The following is a description of a gene set: Mouse Gene Set: REACTOME_METABOLISM_OF_PROTEINS Metabolism of proteins studied in species Mus musculus, and this is the list of marker genes: Mrps21, Rab17, Mgat1, Rps26, Copz2, Jmjd7, Large2, Cul4a, Gfpt1, Rpl36al, Ctsc, Mrpl41, Uqcrc2, Manea, Dcun1d1, Nsf, Abraxas2, Ide, Apol10a, Rab7, Ttll10, Mgat4a, Rps14, Glud1, H4c16 (NCBI Gene Id 674678), Eif2s2, Fut11, Napb, Ddb2, Asb4, Cdca8, St6galnac1, Arf3, Fbxl13, Dolk, Spcs3, Thra, Eif3b, Twnk, Lipt2, Spon1, Actr1a (NCBI Gene Id 54130), Srp14, Wfs1, Mgat4c, Ndufv1, U2af2, Enam, Rpl35a, Eif3j2, Ggcx, Adora2a, Mrps30, Exoc2, Trappc3, Cul3, Ube2s (ubiquitin-conjugating enzyme E2S), Adamts13, Gps1, Eci1, Taf10, Socs6, Neu2, Mbd1, Adamts15, Fbxl7, Thsd1, Dap3, Tectb, Tnip3, Msrb2, Sec11a, Mrpl11, Rpl18, Nrip1, H2bc21, Zdhhc2, Calm1, Apol7b, Ring1, Usp33, St6gal1, Keap1, Uso1, Rpl5, H4c6, Gadd45gip1, H2bc1, Sptan1, Gmppb, Adgrf5, Clspn, Dync1i1, Cnih3, Eef1akmt1, Atp5mg, Ldhd, Usp17ld, Adamts19, Tnip1, Uba1, Galntl6, Psmc2, Mysm1, Cish, Galnt18, Muc6, Mrps15, Pias1, Mrps34, St8sia2, Chst8, Gnb1, Gnb5, Usp42, Rps9, Rab8a, Cdc73, Inhba (NCBI Gene Id 16323), Commd3, Rab25, Mrpl13 (mitochondrial ribosomal protein L13), Rps4x, Vdr, Fbxl16, Nop58, Nedd8, Nod2, St6gal2, Nup155, Dpp4, Aplp2, Dctn2, Mettl22, Spaca4, Trappc9, Notum, Pomc, Rpl35, Cct7, Tmed3, Rpsa, Serpind1, Rplp2, Ctsg, Gpihbp1, Cope, Psme3, Slc34a1, Fbxw17, Bdh1, Slc30a8, Chst10, Ly6d, Smad4, Exoc8, Fkbp8, B3gnt7, Gfpt2, Chchd1, F7, Galntl5, Txn1, H2bc9, Rpl11 (NCBI Gene Id 67025), Traf3, Thsd7a, Ino80c, Eif2s3x (NCBI Gene Id 26905), Fech, Srd5a3, Mrpl42, Nagk, Pdhb, Ube2t, Msrb1, Ube2f, Bard1 (BRCA1 associated RING domain 1), Qsox1, Rora, Ep300, Xrcc4, Sec24d, Oxsm, Arsk, Dhps, Alg12, Hnrnpc, Wdr48, Dync1i2, Pgap1, Mrpl3, Ripk1, Psmb11, Kctd6, Dcaf7, Wdtc1, Dohh, Gan, Prkaca, Tada3, Asb17, Pigz, Mdm2, Etf1, Smad2, Arrb2, Ly6g6c, Usp15, Ube2c, Il6, Ogt, St6galnac2, Pigk, Eif4ebp1, Dctn1, Mrps18c, Usp29, Tuba3b, Eif5b, Gnb4, Srp9, Fcgr4, Cog6, Rpl6, Psg22, Pomk, Esr1, Mme, Asb11, Mrpl55, Dcaf4, Arsj, Sp3, Actr8 (ARP8 actin-related protein 8), Ace (angiotensin I converting enzyme), Apol10b, Slc35c1, Asb6, Polb, Igfbp5, Trappc10, Commd6, Rpl10l, Mrpl52, Socs3, Rab7b, Eif3a, Adamts7, Ttll12, Golgb1, Apc, Rab9b, Dctn3, Alppl2, Hif1a, Ufd1, Skp2, Vnn1, Gngt2 (guanine nucleotide binding protein (G protein), gamma transducing activity polypeptide 2), Ubxn7, Usp30, Fem1b, Lypd2, Klhl5, Commd10, Pex2, Nup188, Ttf1, Sptb, Dctn6, Cnih2, Ube2a, Fbxl19, Cdc20, Copg1, Pex12, Ddx17, Suz12, Ppp6c, Fam20c, Tnks, Tmed2, Hspa9, Chst4 (NCBI Gene Id 26887), F10, Muc15, Galnt4, Klhl20, Ccdc59, Msln, Cog8, Shisa5, Hipk2, Tuba1c, Nup93, Gne (glucosamine (UDP-N-acetyl)-2-epimerase/N-acetylmannosamine kinase, NCBI Gene Id 69688), Psmb5, Ly6g6d, Pex13, Csf1, Asgr2, Spg7, Arg2, Srp54a, Psmc4, Pigw, Lman2, Trappc6b, Tubb4b, Csnk1d, Fgg, Nadk2, Shprh (NCBI Gene Id 70331), Slc34a2, Tada2b, Iars2, Galnt11, Uba6, Ogfod1, Cs (citrate synthase), Izumo1r, Siah2, Proz, Hadh (hydroxyacyl-Coenzyme A dehydrogenase), Fbxw5, Rps19, Galnt9, Usp2, Idh2, Rps10, Nans, Mrps31, Mrps23, Cog3, Btbd1, Gpc3, Usp10, Slc25a5, Pigl, Rnf146, Lrrc41, Dlst, Psma4, Paf1, Pml, Lrr1, Klhl22, Uhrf2, Kbtbd7, B4galt4, Engase, Senp1, Rigi, Rab15, Pias2, H2bc24, Cd59b, Stc2, Pofut2, Hspd1, Atp5po, Nr1h3, Galnt10, Rps27l, St6galnac6, Klhl42, Eif4e, Uchl5, Pigm, Sumf1, Sec22b, Exoc4, Seh1l, Nup88, Spp2, H4c9, Muc4, Yy1, Dmp1, Pros1, Rnf181 (NCBI Gene Id 78347), Usp12, Tubb2a, Nsmce4a, Rps3a1, Rpl26, Eif3e, Igf2 (NCBI Gene Id 16002), Serpinc1, Psme2b, Mxra8 (NCBI Gene Id 74761), Rab43, Psmb6, Cntn3, Pdha1, Ube2d1, Man1a2, Ube2e3, Ranbp2, B4gat1, Blm, Apol8, Sae1, Mrps18a, Usp47, Rps11 (ribosomal protein S11), Stambp, Eif3c, H2bc6, Adamts5, Tshb, Xpnpep2, Nr1i2, Rab20, Gna11, Asb10, Fbxo30, Mrps36, Mrpl44, Eid3, Srp19, Usp9x, Dmbt1, Dph1, Amtn, Mrps22, Asb9, Mrps10, Pccb (NCBI Gene Id 97574), Reck, Arcn1, Mdc1, Tbc1d20, Atp5f1c, Sec24a, Ace2, Arfgap2, Eif5, Usp17lc, Usp13, Ube2k, Tpr, Rps8, Mrpl20 (NCBI Gene Id 73950, mitochondrial ribosomal protein L20), Axin2, Sumf2, Cpm (carboxypeptidase M), Fbxw9, H2ac21 (NCBI Gene Id 632183), Apol7c, Eif2b2, Rbx1, Apol7a, St8sia4, Ube2q2, Prnd, H4c8, Foxk1, Pla2g7, Rnf144a, Apol11a, Trappc1, Ddx5, Dph6, Ccnf, Ino80d, Mrps27, Apoa5, Igf1, Grp, Kdm1b, Drg2 (NCBI Gene Id 13495), Apoe, Rab2b, Vcpkmt, Mmrn1, Asgr1, Cct3, Mrpl46, Ly6h, Rab38, Kin, Lypd1, Psma1, Ffar4, Copb1, Satb2, Foxl2, Nr1h2, Psme2, Capza3, Pias3, Psca, Mrpl4, Gp2, Fbxl8, Usp37, Kdm8, Exoc7, Man2a2, Mbd6, Rps24, Cul4b, Pigp, Gas6, Sspo, Ech1, Chrdl1, Cox5b (cytochrome c oxidase subunit 5B), Cd109, Nrn1l, Wsb1, Ttll8, Rab10, Cog1, Mrpl33, Mia2, Tubb3, Afg3l2, Tpst1, Rab4b, Cops8, Sec23a, Lman1, Atp6ap2, Dcaf5, Rpl36, Gpld1, Cct6a, Eif3i, Usp17le, Rae1, Gcg, H4c12, H4c14, Ube2d2a, Uchl3, Adora2b, Rab13, Rps7, Ccp110, Rps18, Eef1d, Fbxo11, Mrps25, Inha, Alg2, Sec16b, Rangap1, Bmp4, Tmem115, Kdelr3, Psmb2, Trrap, Spcs1, Sec31b, Prkcsh, Rps3, Nfrkb, Alg5, Rab3a, Ikbkg, Rad18, Fuom, Ssbp1, Alg8, Clpp, Fbxo32, Cdc34 (NCBI Gene Id 216150), Rpl7a, Ttll9, Adamtsl2, Plet1, Fstl3, Ube2m (ubiquitin-conjugating enzyme E2M), Otub2, Rab23, Inhbb, Tuba8, Cetn2, C1galt1, Sbspon, Gcnt3, Mrpl17, Asb1, Thy1 (NCBI Gene Id 21838), Gspt2, Tcp1, Igfbp3, Trappc2, Actr10, Dag1, Dcaf8, Btbd6 (BTB domain containing 6), Galnt17, Fbxo22, Spta1, Zc3h15, Mrpl39, Nod1, Asb14, Casp8ap2, Serpina10, H4c1, Ccdc22, Muc5b, Mrps12, H2bc8, Bpifb2, Ceacam1, Klhl9, Rad21, Rgs6, Gng2 (NCBI Gene Id 76292), Asb7, Tubb1, Wdr5, Cmas, Psmb7, Mrps6, Rab36, Rab44, Gip, Srp72, Pomp, Alg9, Adrm1, Psmd9, Fbxw10, Prmt3, Usp18, Brca1, Rps17, Phc1, Rtn4rl2, Lypd5, Mgat2, Rpl13, Alg3, Amfr, Gna15, Napg, Sec22a, Riox1, Tmem132a, Calm3, Eif4g1, H2ac18, Usp19, H2ac4, Top2b, Hdac1, Asb13, B3gntl1, Ube2b, Lep, Rpl22, Stag2, Rpl34, Dolpp1, Thsd7b, Mrpl53, mt-Atp6, Rab1b, Srp54b, Opcml, Dbt, Dcun1d4, Rab27b, Rabggtb, Ctsd, Mrpl38, Pex14, Galnt16, Rpl35rt, Pigb, Psmd7, Stambpl1, Lhb, Ripk2, Pappa2, Cops4, Mrpl1, Adamts14, B3gnt3, Fbxo15, Hcfc1, Ppa2, Rps2, Rab5c, Hmgcs2, Psmg4, Brcc3, Josd1, Ankrd28, Rwdd1, Mbtps1, Wdr20, Rab6a, Fbxl3, Uba52rt, Birc3 (baculoviral IAP repeat-containing 3), St3gal4, Tfpt, Mrpl12, Mul1, Ccna1, Smad7, Ncoa1, Klhl11, Vgf, Stx5a, Fbxo17, Foxo4, Nup85, Bche, Lmcd1, Klhl13, Rab12, Muc16, Asb5, Prkdc, Slc30a5, Usp14, Rpl17, B3gnt9, Plaur, Lgals1, Fbxw8, Eif2b4, Gnat3, Tecta, Aldh1b1, Aco2, Psmc6, Fdx1, Psmd2, Adamtsl5, Pabpc1, Galnt14, Sumo1, Gcnt1, Nup98, Acot2, Ykt6, Sptbn2, Nlrp3, Nup58, Hif3a, Cga, Golm1 (golgi membrane protein 1), Nup37, Ptrh2, Mcrs1, Mrpl49, Bap1, Atxn3, Fbxw7, Cand1, Hsd17b10, Mrpl27, Ube2g1, Mrpl2, Pdk1, Rpl13a, Asxl1, Fbxo9, Gpaa1, Ppara, Otulin, B4galnt2, Traf6, Ppp6r3, Ruvbl1, Gng12, Usp16, Lman2l, H4c11, Apob, Mgat4b, Acat1, Cnih1, Pmm2, Meltf, Ankrd9, H2bc7, Arsi, Ttll5, Usp17la, Sptbn4, Apol9a, Mrps17, Rpl9, Arfgap1, Lman1l, Cd55, Psmb3, Pten, Mrpl37, Thbs2, Tpst2, St8sia6, Sphk1, Galnt13, Tfg, Actr5, Galnt5, Gmds, Rgs7, Mrpl57, Cyld, Men1, Yod1, Chgb, Ppp6r1, Bmp15, Rcn1, Eif3k, Oxa1l, Dync1h1, Eif3j1, Copa, Adamts1, Rpl28, Atp5f1a, Smc1a, Nr3c2, Csnk2a2, Psmd12, Star, Psmg2, Rab14, Mat2b, Alas1, Dnajc24, Fbxo10, Adra2c, Chml, Rpl30, Ube2n, Jmjd4, Gm48551, Adamts3, Ptp4a2, Rab39, Usp34, Rab8b, Mrpl18, Me2, Smad1, Rpl10-ps3, Cst3, Acot1, H2ac19, Scg2, Rpl38, Sec11c, Mrps28, Furin, Fbxl14, Sptbn1, Rab27a, Usp4, Lmo7, Nup54, Dpm2, Rab1a, Rps15 (NCBI Gene Id 20054), Ttll11, Rpl37, Gngt1, Fam20a, St3gal3, Rab21, Galnt1, Mrps33, Muc19, Tgoln1, Eral1, Otud7a, Eef1b2, Psmb4, Leo1, Psg18, Mdm4 (NCBI Gene Id 98570), Rpl31, Rab22a, Arf4, Fshb, Eif3f, Psma3, Kdelr2, Cct4, Man1a (mannosidase 1, alpha), Arf5, Epas1, Bst1, Gcnt7, Kbtbd13, Trp53bp1, Fbxo21, Man2a1, Traf2, St8sia1, Sumo3, Trappc4, H2bc13, Cops5, Mrps7, Nus1, Hsp90b1, Wac, Glt28d2, Adamts2, Tdg, Pigx, Zfp131, Muc21, Rnf168, Park7, Psmb10, Csnk2a1, Fau, Cftr, Gata6, Bcl10, Rpl39, Sdc2, Gpr119, Mmrn2, Smc3, Phc2, Chm, Eef1a1, H4c17, Psmd14, Cbx8, Thrb, Csnk2b, Rab3c, Sema5b, Myc, Mrps14 (mitochondrial ribosomal protein S14), Fbxl5, St8sia5, Psmd11 (NCBI Gene Id 97704), Drg1, Fcsk (fucose kinase), Dcaf10, Fbn1, Nup133, Cox5a, Rpl36a-ps1, St3gal5, Pgm3, Gnb2, Rpl3l (ribosomal protein L3-like), H4c4, Ano8, Atp5pd (ATP synthase peripheral stalk subunit d), Penk, Rpl29, Ttll6, Fbxl20, Rnf40, Folr2, Cd52 (CD52 antigen), Commd2, Nup62, Skp1, Tuba1b, Mrpl40, Oxct1, Dpagt1, Dynll2, Fbxl21, Smad3, Ercc8, Cog4, B4galt2, Hspa8, Ndufs3 (NADH:ubiquinone oxidoreductase core subunit S3), Skic8, Snx3, Psmd13, Negr1, Psma5, Gnpnat1, Psmd1, Usp28, Adra2a, Fut10, Muc13, Psma7, Fuca2, Tubb4a, Copg2, Ube2h, Muc1, Riox2, Hdac4, Dcaf6, Rps27rt, Acad8, Sftpc, Ctsa, P2ry2, Spsb1, Vwa1, Mrpl51, Eif3g, Fpgt, Fbxo31, Dcaf17, Gng11, Afp, Usp20, Mrps9, Dhdds, Thbs1, Eef2kmt, Cct5 (NCBI Gene Id 12465), Ctsz, Preb, Cp (ceruloplasmin), Rpl27a, Pcsk9, Psma6, Neurl2, Rps13, Golga2, Stag1, Mrps18b, Nr1h4, Usp17lb, Pom121, Fbxo7, Rhot1, Sema5a (NCBI Gene Id 320921), Ccna2, Eif4a1, Nup210, Gfus (NCBI Gene Id 22122), Gng7, Gspt1, Socs2, Galnt12, Dcun1d2, Ceacam2, Dcun1d5, Copb2, Rpa1, Fn3k, Suclg2, Lonp1, H2ac25, Rps29, Icmt, Hrc, Dld, Piga, Capza2, Commd1, Fbxo6, Ifih1, Mrps35, Ins1, St3gal6, Rpl10, Commd9, Dctn5, Mitf, Asb8, Zranb1, Klhl3, Lsamp, Igfbp1, Timp1, Scfd1 (NCBI Gene Id 76983), Amelx, Psmg1, Ddb1 (damage specific DNA binding protein 1), Dync1li1, Muc5ac, Cops3, Rnf2, Ubxn1, Rad23a, Rab18, Fgf23, Mcfd2 (NCBI Gene Id 76352), Mrpl58, Emid1, Fn1, Fbxo41, St6galnac5, Birc2, Inhbc, Galnt15, Asxl2, Bmi1, Senp2, Mrpl50, Ubc, Kng2, Mrpl14, Fh1, Nfkbia, Otub1, Gnaq, Art4, Sp100, Psmb1, Commd4, L3mbtl2, Eif2s1, Dctn4, Sec13, Rxra (retinoid X receptor alpha), Rps15a (ribosomal protein S15A), Cma1, Capzb, Rpl19, Pcmt1, Alpl, Tnfaip3, Eef1g, Rad52, Apoa2, St8sia3, Muc2, Rpl3, Trp53, Gbf1, F9, Nup50, Mrps2, Gna14, Proc, Renbp, Tex101, Mrpl24, Arrb1, Rps21, Cdk1, Pigt, Aldh2, Topors, Rpl15, Mrpl43, Dpm1 (dolichyl-phosphate mannosyltransferase subunit 1, catalytic), Foxk2, Tfap2c, Dph3, Mbd5, Fut8, Arf1, Rab32, Ube2w, Rgs9, Eif5a2, Sparcl1, Mrpl47, Ctsh, N6amt1, Lypd8, Napa, Eloc, Rps23, Cop1 (NCBI Gene Id 98306), Prss23, Eif1ax, Ffar1 (NCBI Gene Id 233081), Sprn, Rplp0, Psg29, Actb, Eif2b1, Ing2, Pigf, Uqcrq, Gng13, Rnf20, Galnt2, Ikbke, Mta1, Fbxl18, Trim27, Igfbp6, Ghrl, Nfe2l2, Tulp4, Rpl21, Alb, Smurf2, Pigu, H2ac12, Ndufa13, Nsmce2, Trappc2l, C1galt1c1, Ube2g2, Lias, Folr1, Scg3, Exoc3, F5, Nup205, Calr, H4c2, Gng5, Rpl22l1, Ptcd3, Rpl12, Mrpl48, Mrps26, Htra2, Tnip2, Msra, Rps12, Rab19, Fbxl4, Uchl1, Pcsk1, Fbxo2, H2ac11, Psmc5, Adamts8, Eif3l, Spsb4, Pdia3, Tmed10, Rnf7, Adamts12, Pigg, Ltbp1, Ndufv3, Nup42, Rab35, Eif3h, Fbxo27, Rab40b, Ino80e, Sftpb, Eif4a2, Alg1, Otud3, Ndc1, H2ac10, Psmc1, Il33, Ly6e, Nub1, Herc2, Exoc1, Npl, Sec24b, Pigv, Ces1d, Psmd4, Klhl21, App, Adamts18, H2bc22, Cops7b, Ube2d3, Eif3d, Dph2, Adamtsl4, H2bc11, Sts, Lypd4, Eif2b3, Adamtsl1, Gfm1, Rab40c, Rhoa, B4galt1, Camkmt, Itih2, Rplp1, Asb18, Rpl14, Eif2b5, Vcan, Cops6, Sptbn5, H2ac24, Slc17a5, Rps28, Arsg, Ttll7, Rab11a, Atp5f1b, Pex5, Pdia6, Usp5, St3gal2, Usp7, Pcgf2, H2bc12, Tnks2, Senp5, Inhbe, Gm20716, Igfbp4, Psmd6, Tuba1a, Dcun1d3, H2aj, Rad23b, Napsa (napsin A aspartic peptidase), Abca3, Ahsg, Sec16a, Commd5, Trappc5, H2ac20, Satb1, Sar1b, Areg, Pdcl, Bglap2, Map3k7, C3, C4b, Megf6, Ttll13, Mpi, Tgfbr1, Gng3, Pex10, Asb16 (ankyrin repeat and SOCS box-containing 16), Fbxw11, Psmd3, Dynll1, B3gnt5, Aurkb, Usp22, St6galnac4, Eef1akmt2, Rab39b, Clpx, Jmjd6, Tgfa, Spsb3, Rab30, Pign, Otoa, Tomm20, Commd8, H2bc4, Pmm1 (NCBI Gene Id 97953), Tnc, Kat2b, Safb, Neu4, H2bc3, H2ac6, Ttll3, Ckap4, H2ac23, Ntm, Ppa1, Pomt2, Ctbp1, Rab33a, Rab4a, Apol11b, Mvd, Nfu1, Adamtsl3, Hgs, Amdhd2, Bet1, Dtl, Tuba4a, Smdt1, Pomt1, Rela, Cog5, Sftpa1, Galnt3, Gh, Man1c1, Prss41, Eif4b, Ctr9, Mrtfa, Trappc6a (trafficking protein particle complex 6A), Usp44, Dpm3, F2, Derl1, Psmd8, Actl6a, H4c18, Mrpl32, Nup43, Sec22c, Stx17, Calm2, Fbxl15, Umod, Alg14, Akp3, Gfm2, Prss21, Nup35 (nucleoporin 35), Ambn, Adamts9, Cops7a, Eif3m, Ndufs1, Spsb2, B3gnt6, Rps6, Tomm70a, Neu3, Galnt7, Rab33b, Rps16, Atp5pf, Adamts20, Rpl39l, Cpb2, Nudt14, Tmed7, Rpl37a, Serpina1c, Pcna, Gng10, Usp21, Asb12, Rpl23a, Mrpl34, Tmed9, Rbbp5, Nrn1, Adamts16, Copz1 (coatomer protein complex, subunit zeta 1), Klhl41, H2bc15, Pmpca, Ino80b, Muc20, Rab37, Sec23ip, H2ac8, Rab9, Enpep, H2ac22, Ttll2, Trf, Mrps11 (NCBI Gene Id 97380), Prkn, Hdac7, Ube2i, Dlat, Art3, Abraxas1, Sec31a, Josd2, Mpdu1, Alg6, Dnmt3b, H2ac1, Galnt6, Gcnt4 (glucosaminyl (N-acetyl) transferase 4, core 2 (beta-1,6-N-acetylglucosaminyltransferase)), B3gnt4, Apeh, Gng4, Vcpip1, Vhl, Gnb3, Vdac1, Cul1, Ubd, Gorasp1, Igfbp2, Usp26, Idh3a, Nae1 (NCBI Gene Id 260355), Rab6b, Nup214, Ren1, Nup107, Mrpl10, Rpl4, Rpl7, Mrrf, Scmh1, Usp3, Lypd3, Dync1li2, Lypd6b, Kctd7, Rab29, Mettl21a, Neu1, Rab2a, Fbxw2, Klhl2, Rccd1, Cog7, Rab26, Dnmt1, Mfge8, B3gnt8, Ogdh, Ank1, Etfbkmt, Babam1, Ktn1, Cntn5, Col7a1, Exoc5 (exocyst complex component 5), Cog2, Pomgnt1, Adamts4, Tab1, Mepe, Pigs, Thsd4, Fem1c, mt-Co1 (mitochondrially encoded cytochrome c oxidase I), Usp8, Atxn7, Phc3, Nanp, Rpl18a (NCBI Gene Id 76808), Fbxw4, Igfbp7, Mrps24, Cbx4 (NCBI Gene Id 12418), Hk1, Slc35a1, Mrpl22, St3gal1, Mrpl15, Canx, Mrpl35, Pias4, Smc5, Pigyl, Rnf128, Calu, Vdac2, Sec24c, Eif4h, H2ac13, Rnf123, Kat2a, Rpl24, Uba2, Mrps5, Dnajc3, Rraga, Xpc, Rwdd2b, Elob, Adamts10, Pgr, Parp1, Rps27a, Stam2, Nr3c1, Psmg3, Ero1b, Aurkaip1 (aurora kinase A interacting protein 1), Kbtbd8, B4galt5, Rgs11, Aaas, Senp8, H2ac7, Mrpl45, Dph5, Large1, Uba3, Ndufab1, Mrpl23, Cpb1, Ube2r2, Arsb, Ube2z, Rab34, Acadsb, Spcs2, Mdh2, Top1, B3galnt2, Arsa, Cdh2, Mrpl36, Pomgnt2, Hnrnpk, Nr5a1, Mrpl30, Serpina1b, B3glct, A4gnt, Kdelr1, Spon2, Top2a, Rab24, Pappa, Taf9b, Ndufa2, Nup160, Ube2v2, Tubb6, Adrb2, Gosr2, Apol7e, Tfam, Uap1, Nup153, Acot3, Eef2, Usp25, Psmb8, P4hb, Matn3, Nucb1, Ngly1, Rab5a, Rab3b, Cbx2, Tuba3a, Rara, Rps20, Apol9b, Ar, Usp11, Tubb2b, Msrb3, H2bc14, B4galt3, Nsmce3, Rbbp7, Cul2, Fuca1, Bet1l, H4c3, Ubb, Uimc1, Pigq, Mrps16 (NCBI Gene Id 66242), Rpl36a, Rab3d, Alpi, Ino80, Cct6b, Rpl27, Suds3, Glb1, Nploc4, Mia3, Srp68, Rpl8, Daxx, Fn3krp (fructosamine 3 kinase related protein), Nr5a2, Fem1a, Mrpl54, Becn1, Mboat4, B3gnt2 (NCBI Gene Id 85024), Fbxo40, Cops2, Cpa3, Mrpl21, Rpl32, Rab31, Uba52, Pigh, Rps25, Fbxl12, Acot5, St6galnac3, Ube2l3, Gm6525, Mdga1 (MAM domain containing glycosylphosphatidylinositol anchor 1), Vdac3, Rpl23, Rab5b, H2bc23, Gata3, Rps27, Stam, Npm1, Babam2, Etfb, Rps5, Ube2e1, Sumo2, Gcsh, Hltf, Ly6k, Klhl25, Agt, Mgat5, Arfgap3, Apoa1, Dda1, Socs5 (NCBI Gene Id 69052), Mrpl28, Cfp, Gria1, Sftpd, Cct8, Adamts17, Psmd10, Incenp, Fga, Pnpla2, Rab11b, Cct2, Fstl1, Tubal3, Wsb2, Mrpl9, H2ac15, Dcaf13, Eif5a, Usp48, Gng8, Rnf152, Pigc, Commd7, Fbxo44, Psme1, Psmc3, Vcp, Otud7b, Ccn1, Fbxo4, Smc6, Rce1, Gosr1, Psmd5, Ttll4, Nfkb2, Mtrf1l, Trmt112 (tRNA methyltransferase 11-2), Hic1, Usp24, Cdc25a, Mrpl19, Dcaf11, Nsmce1, Axin1, Sin3a, F8, Lipt1, B4galt6, Aldh18a1, Mrpl16, Psma2, Spp1, Muc17, Adamts6, Adam10, Shmt2 (serine hydroxymethyltransferase 2 (mitochondrial)), Rabggta, Mgat3, Gmppa